Given this list of marker genes Avpr1a, Pgam1 (NCBI Gene Id 68006), Arhgef26, Tle1, Aspn, Lmo4, Trim2, Cfap144, Pdgfd, Cbr2, Or2ak6, Fgfr2, Fgf10, Loxl2, Pgk1 (phosphoglycerate kinase 1), Maob, Klf15, Cyp1b1, Raly, Atp1a1, Pid1, Maff, Gadd45g, Tanc1, Kctd12b, Sesn1, Stat5a, Myf5, Fndc3b, Wif1, Ly6d, Cxcl14, Gm10237, Sfrp2, Col4a6, Ahnak, Tmem45a, Epha3, Fzd7, Nt5e, Lrp4, Acot1, Egln3, Trp53inp1, Pros1, Pmaip1, Nlgn1, Rgs2, Hspa1a, Sox9, Fkbp5, Dclk2, Bcl6, Mkx (NCBI Gene Id 210719), Pdgfc, Pla2g4a, Tfap2c, Slc2a1, Lamp2, Lrrk1 (leucine-rich repeat kinase 1), Xlr3c, Calcrl, Adamdec1, Col23a1, Smoc1, Neat1, Bdh2, Arc, Arl6ip5, Ncoa1, Efemp1 (NCBI Gene Id 216616), Filip1, Cdh1, Cebpd, Dner (delta/notch-like EGF repeat containing), Trp63 (NCBI Gene Id 22061), Maf, Lmcd1, Cidea, Klf9, Zfas1, Setbp1, Tmem100, Igfbp2, Shh (NCBI Gene Id 20423), Bnip3, Taf1d, Ube4a, Pdlim3, Kcnd2, Tac1, Aldh1a3, Penk, Itgb4, Pnpt1, Mpst, Foxf2, Slc39a8 (solute carrier family 39 (metal ion transporter), member 8), Tmem242, Slitrk6, Cys1, Snrpd3 (NCBI Gene Id 78379), Col24a1 (NCBI Gene Id 71355), Rasl11b, Ceacam1, Tspan1, Colec12 (collectin sub-family member 12), Errfi1, Fabp4, Glul, Wwp1, Emd, Map3k6, Synpr, here is a description of the gene set: Cancer cells differentiate along specific lineages that largely determine their clinical and biologic behavior. Distinct cancer phenotypes from different cells and organs likely result from unique gene expression repertoires established in the embryo and maintained after malignant transformation. We used comprehensive gene expression analysis to examine this concept in the prostate, an organ with a tractable developmental program and a high propensity for cancer. We focused on gene expression in the murine prostate rudiment at three time points during the first 48 h of exposure to androgen, which initiates proliferation and invasion of prostate epithelial buds into surrounding urogenital sinus mesenchyme. Here, we show that androgen exposure regulates genes previously implicated in prostate carcinogenesis comprising pathways for the phosphatase and tensin homolog (PTEN), fibroblast growth factor (FGF)/mitogen-activated protein kinase (MAPK), and Wnt signaling along with cellular programs regulating such 'hallmarks' of cancer as angiogenesis, apoptosis, migration and proliferation. We found statistically significant evidence for novel androgen-induced gene regulation events that establish and/or maintain prostate cell fate. These include modulation of gene expression through microRNAs, expression of specific transcription factors, and regulation of their predicted targets. By querying public gene expression databases from other tissues, we found that rather than generally characterizing androgen exposure or epithelial budding, the early prostate development program more closely resembles the program for human prostate cancer. Most importantly, early androgen-regulated genes and functional themes associated with prostate development were highly enriched in contrasts between increasingly lethal forms of prostate cancer, confirming a 'reactivation' of embryonic pathways for proliferation and invasion in prostate cancer progression. Among the genes with the most significant links to the development and cancer, we highlight coordinate induction of the transcription factor Sox9 and suppression of the proapoptotic phospholipid-binding protein Annexin A1 that link early prostate development to early prostate carcinogenesis. These results credential early prostate development as a reliable and valid model system for the investigation of genes and pathways that drive prostate cancer. from publication Schaeffer EM, Marchionni L, Huang Z, Simons B, Blackman A, Yu W, Parmigiani G, Berman DM (PMID 18794802) Genes up-regulated in the urogenital sinus (UGS) of day E16 females exposed to the androgen dihydrotestosterone for 12 h. Mouse Gene Set: SCHAEFFER_PROSTATE_DEVELOPMENT_12HR_UP studied in species Mus musculus